The following is a description of a gene set: A process that is carried out at the cellular level which results in the assembly, arrangement of constituent parts, or disassembly of cytoskeletal structures comprising septin complexes and their associated proteins. studied in species Homo sapiens Human Gene Set: GOBP_SEPTIN_CYTOSKELETON_ORGANIZATION, and this is the list of marker genes: SEPTIN9, RTKN, WDPCP, ANLN, LRCH3, DCHS1